Given this list of marker genes ZNF565, ENSG00000232884, CAD (carbamoyl-phosphate synthetase 2, aspartate transcarbamylase, and dihydroorotase), MBTPS1 (NCBI Gene Id 8720), DNHD1, SIN3B, SLC4A2, MAPKAPK3, CDK5RAP2, TIGD4, CDC5L, ANKFY1, BTN2A2, CARNMT1, C11orf68, MKLN1, GDF15, RNA5SP399, LINC00885, GTF2IP22, TMEM132D-AS1, ATPSCKMT, NR1D2, FNBP4, RPL30P11, OGDH (oxoglutarate dehydrogenase), MBTPS1-DT, KLKP1, ATL2, GSTCD, HOXC6, STAG3L2, DNM1, SPRY3, PDE4A, DERL3, LRRC8D, DNAJB4, SPMIP8, CARM1, RBL1, SNORD58B, LETM1, RNU6-353P, SLC15A1, C5orf34, NOL11, OSER1-DT, PCAT19, RPS15 (ribosomal protein S15), MGME1, PSMD5, CEP89, MSRB2, IFNAR1, ENSG00000271860, TGM2, EP400P1, MAN2C1, FGF13, FAM50A, B4GALT2, MDK, POLR2I, DDX11, EIF2AK3-DT, ERRFI1-DT, RNA5SP324, RPA3, TAB3, HSPG2, ATP5MFP2, NCOA4, CD46P1, MAP3K14-AS1, AKAP11 (NCBI Gene Id 79988), RPL12, RRP15, HMGN1P32, MYO6, DYNC2I2, LINC01257, NOP14, FGD2 (NCBI Gene Id 221472), AZGP1 (NCBI Gene Id 90053), ITGA2B, RPS18, INTS10, FKBP14, BRINP2, OR10V3P, CCND3, SHOC2, ENSG00000244791, TMCO1, DNTTIP1, BLTP3B, TSPAN1, CD59, IREB2, CCDC137, CBX3P4, ARMH4, PTEN, CHAF1A, PIK3AP1, KRT8, ERBIN-DT, MIR4441, PEAK1, FEM1C, FGFR1OP2, MEMO1, MXI1, XPO1, DCTN2, WRAP53, FAAHP1, FHL1P1, TMEM101, ZBTB22, ASB13, ZNF317, ITGA3, CREB3L1, EIF4A3, ANKS6, MXD1, ATG4B, FKBP8, LPAR5, THBS3-AS1, CYGB, SPATA3, TTC13, NADK2, RNVU1-25, MAP3K7, LINC01694 (long intergenic non-protein coding RNA 1694), ZFAND3, OBSL1, ZNF138, HIVEP2-DT, MDH2, ANO8, STK16, SCAMP5, HBE1, CHMP1A, DGKZ, MGAT1, RBM26-AS1, CCDC59, LRSAM1, LRP2, ERICH6-AS1, ZNF143-AS1, UBE2V1P4, ZNF236, RBPJ, RORA-AS1, UFSP1, BTF3P9, POLR1C, DCAF6, MT-CO1, TAOK1, RNF223, CCDC22, CNN2, RPS8, MTMR4, ARHGEF1, TPP1, INPP5D, TSPOAP1, LINC00963 (long intergenic non-protein coding RNA 963), MARCHF6, GAS8, CNGB1, UBTF, VPS54, EFHB, MIR4703, LINC00958, POLR3C, MIR616, ARFGEF2, FSD1, CDK2AP2, CLIC4, CDK1, SLC25A6, RNF115, CCDC192, PXMP4, XPC, RPS20, STAT6, MT-CO2, BCAR3, BCL3, SAXO1, PUS1, OR1AB1P (NCBI Gene Id 81090), CELF4, ZNF77, HDDC2, LINC01732, NUDT16 (nudix hydrolase 16), KCNAB2, NCAPG, GET4, SLC13A3, NSDHL, ARRDC3, CLEC16A (NCBI Gene Id 441746), CLCN2, PRR11, TSC22D1, PTPN4, RANBP1, C7orf50, ZNF202, PNPLA6, CRKL, OR13A1, WDR73, RSAD2, LINC03068, PPP4R3B-DT, E2F1, CYP2S1, PCNA, ARFIP1, ENSG00000187951, C8orf74 (chromosome 8 open reading frame 74), GPCPD1, TBC1D4, RASA4CP, BRF1, MIR1205, UPP1, SLC35E2A, HMGCS1, LINC01547, SCIRT, CHMP4C, RARG, PHLDB1, FSIP1, ZNF83, VWA5A, ZNF490, DLGAP4, USP49, SEMA5B, TCP11, ENSG00000260592, MIR548AW, HSP90AA1, IK, ICA1, CMTM3, GBE1, NLRP1, TRIM56, ALKBH3-AS1, PPM1K, MPND, MYO1A, AGBL3, MIR4659B, MDGA1, EOLA1-DT, IL6R, TMEM79, WDR64, TRGV6, DCAF11, USP27X, TMEM9, CFAP251, PAXBP1, SEC63, HMGN2P18, ASPHD1, ARF3, PA2G4, MYO18B, CDC20, TANK, SPN, TARDBP, LINC02842, DUSP10, PUDP, H4C3, LEF1, NDUFAF3, RIPOR3-AS1, ACSL3, DDB2, ATP6AP1L, GNAL, ODC1, SSR4P1, TMEM37, CCDC144CP, TLE6, CBY2, ZNF3, STK38, PLA2G6, RNU1-58P, UTP3, RIMBP3, TLK2, DENND2B, FHIP2B, DHRS13, HNRNPH3, ABLIM3, CELSR2, DCXR, USP27X-DT (USP27X divergent transcript), NUDT16-DT (NUDT16 divergent transcript), ZNF587, ADAMTS10, NMNAT1P5, ELOCP2, HSP90B1, TLCD1, CSNK1D, PPP6R1, ABCB9, ATP5MC1, FCER2, HOXC5, RPS2, ZNF609, MRE11, MIR3189, RPS11, KCNIP2-AS1, TMEM204, PPP2R5C, RCAN1, NME1, SHLD2, FABP5P3, BMAL1, FSCN2, PEX12, SUSD3, RPS6KA1, SYT7, CSTF3-DT, THAP1, SLC35E4, ENSG00000253986, GALNT4, CCDC91, TTI2, HDAC8, MIR6076, ZFYVE28, GPAT4, PIH1D2, SRP19, MAD1L1, CHCHD5, ERAP1, ZNF286A-TBC1D26, COX11, ATOX1, TBC1D10B, TMEM116, NFKBIE, SNRPB, ATF7-NPFF, RNU2-63P, MIR4530, EIF5, LTBP2, PLK1, SECISBP2L, ZP3, PRKAR1A, ADD3-AS1, HSPBAP1, WDR25, STK10, BTBD10 (BTB domain containing 10), PRSS8, CUX1, LINC01055, FLJ46284, HERC2P2, RNVU1-19, P4HB, CAMTA1-DT, HERC5, USP30, MBNL1, GLIS2-AS1, KAZALD1, RNU2-2P, INTS12 (integrator complex subunit 12), ZC3H12A, SRCAP (NCBI Gene Id 10847), GBA1 (NCBI Gene Id 82008), LINC02281, LEF1-AS1, NR2C2AP, RMC1, ZNF45, IGHA2, COG5, ALG2, DCXR-DT, MARCHF2, SLC3A2, TTYH1, ZNF574, ZNF212 (NCBI Gene Id 7988), NME2, MYH11, COPZ1, SH2B3, PLXND1, CIC, PLCD1, MIR548AX, DRAP1, PHC2, CLK3, INHA, EPS8L1, UIMC1, MICOS10-NBL1, ECI1, DCP1A, MYADM-AS1, WDR27, TRIP4, SYNCRIP, TCP11L2, HSPB1P2, CDT1, DNAJC16, PGA3, CRNDE (colorectal neoplasia differentially expressed), MT-TW, RAD1, ZNF274, RNVU1-6, LYPD5, DIXDC1, PHYH, TTC32, RAB30-DT, RBPJL, TYMS, ATP6V1H, SDR39U1, PLEKHG5, PPP4R3B, SNHG30, MFAP4, LINC00475, SPIRE2, PRKCSH, HMGN1, SF1, CDKL3, MELTF, SHISA5, RNA5SP428, ICE2, ELOVL1, HPCAL1, AHI1, DDX11-AS1, PIP4P1, TIGD1, DALRD3 (NCBI Gene Id 55152), NRSN2-AS1, CYTH4, EPCIP-AS1, ARRDC3-AS1, POLR2H, WDR62, BCAP29, EPM2AIP1, KPNB1-DT, ADO, SRGAP2, SLC12A2, ANKRD13C-DT, CELF3, OFD1, KLK10, SRGAP2C, SPCS2P3, UCKL1, UBE2D3-AS1, PRR5, TMEM248, SMPD4P1, BAHCC1, TCP10L2, CDC42SE1, COQ7-DT, LPXN, NUP155, DNPEP-AS1, CNPY1, TFAM (NCBI Gene Id 8033), BLTP3B-DT, WSB1, CCNI, PPM1K-DT, PHF5A, NPHS1, NEK2, MIR17HG, MTF2, COX7B, H3-3B (H3.3 histone B), ABHD2, LCNL1, UCP2, ABCC5, MAK16, HIVEP3, GOLGA1, ATF7IP (NCBI Gene Id 55729), NSL1, ANKRD49, MTMR8, ENAH, KDM4A, PSMD9, SMG1, ERRFI1, SLC25A28-DT, MIR3124, ZNF844, IMP3, LINC02863, TCF25, MAN2A2, CAMTA1, CSAG1, VMP1, CYBRD1, MIB2, SMG7-AS1, RNF145, CCND2, EXOSC10-AS1, SMG5, CAPN1-AS1, DVL1, TBC1D5, CAND1, SPRR2D, CHCHD2P1, MYLK, APLP1, CAMKMT, PIMREG, F12, RRAGA, HBD, RFC5, CCDC144A, LINC01518, ARV1, RPL27A, MIR5087, ETF1, PIP5K1C, SMG7, CREM, SOCS1, COL5A1, FAM83C, NLRC5 (NLR family CARD domain containing 5), CIAPIN1, CIMIP4, RPS7, NECAP1, LNCTSI, APLP2, NECTIN1, ZNF556, CHTF8, RPS6KC1, ITGB2-AS1, STXBP2, NELFCD (NCBI Gene Id 51497), QRICH1, PPAT, ARID3C, ZNF680, ZNF655, RCOR3, NAA35, ACSL1 (NCBI Gene Id 91249), NPTN, ZCCHC24, DHRS3, SNHG16, AGPAT3, DGLUCY, CCDC159 (coiled-coil domain containing 159, NCBI Gene Id 126075), ARAP3, ELF1, GTF2IP4, SEPTIN5, RNVU1-21, RPS5P2, BANF2, NOS3, CHD9NB, UTP4, INO80C, PLEKHA8, VDAC2P3, LINC00552, RAB5B, VAMP2 (vesicle associated membrane protein 2), MIR4522, SNORD1B, GPATCH3, ZBED5-AS1, FAM200B, RPTOR, FOXK2, HASPIN, RABGAP1L, IL17C, PDXK, PPM1B-DT, RPS21P8, ARID4A, CMPK2, GNG4, RPS17P5, PSMD4, RPL17, FMR1, FBXL5, N4BP1, MTND5P11 (NCBI Gene Id 100506169), LINC00933, CCN1, MPV17L2, C6orf120, ENSG00000255647, POP1, S100PBP, AQP1, AGRN, ERGIC2, C17orf58, SKA2, TBCB, INSR, SARAF, FAM170B-AS1, SCIN, SPTAN1, FOXS1, NMU, FUBP1, MARK4 (NCBI Gene Id 57787), LRRC37B, NUP62CL, MT-TD, TBCCD1, ZFP64, TCF4, SHOX2 (SHOX homeobox 2), GFI1B, CCZ1 (NCBI Gene Id 51622), MRC2, RNU5E-4P, MACC1, MT-TA, HMOX1, PAICS, MED1, FAM72A, KCNE3, GRB10, KLC3, NSUN3, MBD6, TJP3, TBL1X, RIDA, SCN1B, GPR179, IGSF9B (immunoglobulin superfamily member 9B), MET, INPP1, MIR4276, MIR3681HG, ATF7, RNU6-1069P, E2F3, MT-TN, ATP5F1C, SLC16A9, TMEM169, TAL1, NME1-NME2 (NME1-NME2 readthrough), ALKBH7, OR51B5 (olfactory receptor family 51 subfamily B member 5), DHX37, LINC02050, NSMF, RNVU1-28, MICOS10, ASH2L, ESR2, FHIT, DNAJB11, CASZ1, BZW1, DHX36, LINC01841, ENSG00000235480, HMGN2, NPEPL1, MICALL2, AGPAT1, LINC00899, ADNP, CIB1, GATAD2A, UPF3A, LIMS2, SLC43A2, ERCC6L2, HSPD1, HMGB2, LINC02288, DCAF16, CAPN7, ZNF441, ZNF263, RAB30, TM4SF19-AS1, SUZ12P1, LRFN4 (leucine rich repeat and fibronectin type III domain containing 4), BRWD1, ARHGAP22, NFYA, RN7SKP192, ASXL1, LINC01775, SUGP1, VTRNA1-1, COASY, ARHGAP11B-DT, MT-TQ, RNU7-124P, NRSN2, ZNF44, ANKRD17, BIVM (NCBI Gene Id 54841), CTCFL, ITGAE, NIF3L1, EXOC1, FAM72B, PURB, PLSCR3, CSRNP2, SLC39A3, DNAJB2, PIP4P2, GSTA4, ANP32E, DDX20, SUPT5H, MAD2L2, SLC49A3, ZNF346, ANXA2, CACNA1A, ACTN4, RXRB, PLK5, RNPC3, SLC29A1, CNTROB, STXBP4, TRPM4, ABCC3, ADAT1, SLC2A1, DDX60L, TTC41P, RUVBL2, EIF4A1P9, TEDC1, PTPA, NEPRO (NCBI Gene Id 285338), GABPB2, SEC61B, IQCN, RABAC1, ERCC6L2-AS1, ODC1-DT, KIAA2013, DNMT1, GPR17, MYADM, RGR, CXXC4-AS1, ENOX2, PHC1, NOL9, ZFP91-CNTF, GSS, DENR, LINC01145, GYPB, ZNF626, WNT3, TUBA1C, LINC01700, LRP3, KCNIP2, RIMBP3B, ERICH6, TRG-AS1 (NCBI Gene Id 100506776), TIPIN, CENPBD2P (NCBI Gene Id 65996), C1orf105, FGF1, CEACAM7, ACADSB, RPS27P30, RN7SL79P, TGOLN2, LMO2, AMD1P4, SEMA3B, TCEA2, TUFT1, SLC25A39, RBM17, CD226, CLIC2 (NCBI Gene Id 1193), PTP4A1, TUBGCP5, TDRKH, KIF2A, SCGB1A1, H1-2, PMS2, ZCWPW1, FAM200A, PHC2-AS1, FAR1, THADA, PKM, SYN3, VAC14, TRIM41, GTPBP3, TMC6, SYNPO, PTPN7, OXLD1, SLC39A11, ICMT, GRK1, TRAPPC2, MALAT1, SLX9, FAM157C, IKZF5, CCT8, NCOR2, CCDC9, RAB26 (RAB26, member RAS oncogene family), PSMA3-AS1, RNU6-1106P, LIMS1, FBXL8, GCK, BMS1P1, TTC3, IL4R, S1PR2, HOXC9, ATXN7L2, EMP3, TSSC2, CSTF3, PES1, AFF4-DT (AFF4 divergent transcript), PCED1B-AS1, RAP2C, HIF1A, RBBP5, ZNF286A, COTL1, RPSAP5 (NCBI Gene Id 319129), SLC15A3, NDUFV1-DT, XIST, KLC2-AS2, AP1G1, MORN5, UQCRB, DMTF1-AS1, RNPC3-DT, CR1L, RPL7A, ADGRE5, SNORD101, YIPF3, ENSG00000248607, FAM135A, GALNT7, LSM14A, EBAG9, FOXK1, UBE2D3, UBE2E1, SH3BP5L, CTSK, GAA, DYNC2LI1, CEP350, CCDC144BP, YARS1, MAU2, TSC22D4, MLH1, TMEM100, AKNA, LINC01169, MED28, DNAAF6, PCBD1, FAT1, HDAC5, COQ9, ZNF280B, ZSCAN25, DNAI7, STAT1, AXL, CD34, ARHGDIG, MIR4733, XPO6, LRRC46, ZNF101, H2BC15, SLC39A7, RPS9, SPPL2A, DNPEP, GP1BB, ANKRD36B, TMEM156, FBXO44, SNORA78, PSMC5, ICMT-DT, DYRK4, GSDMD, GIPC2, ACVR2A, PRDX6, CLCN3, EFHD1, CENPT, MT-CYB (NCBI Gene Id 4519), PCMTD1, LINC00620, MAGED2, UBE2Q2P1, MIR3154, NDUFB10P1, GEN1, THAP4, PRO1804, LRRC28, CNOT1, SPATA33, RHPN2, SF3B4, ATAD3B, CD68, ROM1, LINC00957, POC1B, LUC7L2, PHF23, BRSK1, GDF11 (NCBI Gene Id 10546), ENSG00000239008, FCHSD2, PRPSAP2, IGF2BP3, PTTG1IP, HSF1, BANP, LINC02327, RN7SL659P (NCBI Gene Id 106479462), ITPR1, MGRN1, PPCDC, KEAP1, TCP11L1, CHUK-DT, ZMIZ1-AS1, KIN, WDR20, RPL10A, PRDX1, BLOC1S2, SLC25A33, JOSD2, RUSC1, COL4A2, TMEM183A, PECR, DHFR2, CAMK2N2, GON4L, CTNNA2, GYPE, WBP1, RPL17-C18orf32, CDH15, RRS1-DT, CLPTM1L, MAGEA12, ZSCAN18 (NCBI Gene Id 65982), MIR7-3HG, ZNF136, SMARCD2, ACBD4, TRPV3, SF3A3, DLL4, LINC02371, EIF4E2, ACSM5, ZNF146, DBN1, CHD4, VPS33A, LMNA, STAP2, LSM10, GNG8 (G protein subunit gamma 8), CEBPA-DT, CAPN1, KPNB1, SRSF10 (NCBI Gene Id 89048), NRL, PCLAF, RN7SKP219, IMPA1, PAPLN, ACCS, SEC62, MRPL57, SAMD14, NFYC, STRIP1, NFIX, VWA7, USP54, ADGRB2, EGLN3, PHF19, PLEKHG2, ZFAND3-DT, GART, FCHSD1, SDSL, CDK12, LINC02129, FBXO17, INTS9, HSPE1-MOB4, TDRKH-AS1, DAXX, ZNF131, SNX12, HIBCH, DMAP1, MED22, RNA5SP505, EIF4G1, YJU2, ZNF292, ACHE, WNT10A, UCA1-AS1, ZNF582, SPTSSA, FAAP20, LTV1, SCARB1, CCNC, EIF3H, CSAG4, EXOC6, SLC12A2-DT, HTR5A, APBA2 (amyloid beta precursor protein binding family A member 2), RNFT2, LMTK3, RN7SL444P, LINC03008 (NCBI Gene Id 100128325), OPN4, KMT2C, ZZZ3, GNAS, PKIB, RBM39, KCNH2, SNORD38A, TBL1XR1, MT-TC, LINC02783, AP3M2, LRAT, RAPGEF1, SLC27A1, MECOM, PSIP1, EIF2AK3, TOP3B, RBM26, CCAR2, FURIN, SEPTIN7, GJC2, ACAP3 (ArfGAP with coiled-coil, ankyrin repeat and PH domains 3), DOLPP1, RPS12, PARP12, ETFA, CRAT, RNU1-1, CIMIP5, PURG, CYP4Z1, RN7SL346P, ZNF736, GTF3C1, TMEM18, CYB5D1, RPL30P5, BAGE2, MPC2, LINC00431, LINC01399, MYO9B, SMNDC1, ENSG00000259182, VDAC3, SLC35E1, CMIP, TMEM209, GLB1L, ADA, RNU6-240P, VARS2, KLHDC9 (NCBI Gene Id 126823), NKAPD1 (NCBI Gene Id 55216, NKAP domain containing 1), VILL, ACBD5, SNHG32, OSER1, TICRR, PNCK, CLASRP, GCHFR (NCBI Gene Id 2644), RNU6ATAC, ACO2, GCDH, PCSK7, ENSG00000233017, SPOPL-DT, ZNF100, PCED1A, SNX5, VPS33B-DT, AURKAIP1, SPRED1, DDR1, CCDC12, MAPK14, PJVK (pejvakin), CATSPERG, SLC26A8, FAM174C, SF1-DT, GMFB, MOV10L1, CPEB4, PGP, CAPN3, CDC20-DT, H4C5, UBALD2, CORO6, NLRP7, FAM83F, NCSTN, SIPA1L1, NME4, SLC38A8, SLC41A3, TFAP4, GRK6 (NCBI Gene Id 2870), PRKAB1, KDM2A, ZNF48, NDUFV1, SMARCD3 (NCBI Gene Id 6604), PPIL3, USP22, LINC02525, TMEM117, ZNF428, GABBR2, GAS5, METTL25, BAIAP3, TCN2, DBR1, ATP1B2, TSC1, GORASP2, RPS2P4 (ribosomal protein S2 pseudogene 4), GCC2, EMD, UBE2I, PSD2-AS1, PSMB6, DYNLT2B, TMCO1-AS1, INAFM1, RNU6-268P, ANK3, LIN28B, INKA2, INTS9-AS1, FTSJ3, DGUOK, TSPAN32, SLC29A4, ZNF442, CAND2, SLC22A18, CDS2, NECAB2, EML3, RPS19, MSX1, TTC32-DT, SNHG9, BAIAP2, AKR1E2, ZNF433-AS1, ZNF254, NDUFA2, B3GALT1-AS1, ICA1-AS1, ZFP36L1, HISLA, ARL13B, SLC16A6, PUF60, RC3H2, ARHGEF2, ACOT7, NDUFA8, LINC01132 (long intergenic non-protein coding RNA 1132), GDPGP1, TMCO4, WBP4, ZNF143 (NCBI Gene Id 7702), FAR1-IT1, RPS6, CETN2, NECTIN2, POC1B-AS1, TDH, MAEA, ARID1A, ZBTB37, MATR3, FDXR, LINC02882, SKA3, RNF139-DT, EPS15L1, RRS1, SELENOW, JPX, RAC1 (NCBI Gene Id 5879), XPO4, ZNF513, SRRT, VRK2, LINC01719, SUSD6, RAB40B, HERC2, GDPD3, HSPE1P3, C1orf54, KMT2A, SLC43A3, NAA38, MIR3667HG, C6orf89, SYNGR2P1, MIR7-3, SHPRH, ZNF76, HBG2, DRAIC, RNU4-13P, OGA, TRAPPC1, MTCO3P12, ALDH9A1, PPP1R9B, SUMO2P17, TIMM17A, MICOS10-DT, GSK3B-DT, HSP90AB1, RAPGEFL1, ENSG00000273727, SARS2, MIR6802, MMS22L, RNF167, OARD1, ANKRD13C, MAP2K2, FKBP4, HMG20A, TYK2, TMA7B, CLSTN1, LINC01029, ELAVL1, FAAP24, SPC24, TYRO3, HMGN4, TNFSF14, TSPYL6, CCNT1, DAZAP1, AHCTF1, SOX6, MED28-DT, MYL11, ZNF663P, TBC1D3P5, DPP9, PUS1-AS1, IRF9, LTBP4, DCAF4, ECE1, CHID1, INTS13, SLC15A4, C10orf88, CMTM4, HMGN2P34, UACA, ZBED5, MAGOH, USP1, RENBP, BABAM1, DNAJC6, C1orf159, PDZK1IP1, ETS2 (NCBI Gene Id 2114), GRK4, SNORD48, ENSG00000259881, EOLA1, CSDE1, ZKSCAN2, GALM, SMG6, TENT2, ASH1L, BAZ2A, NRBF2, ADARB1, HNRNPH1, AMER1, HSPBP1, TFRC, RNU6-1136P, SLC25A4, TRAJ7, GCNA, NUP35P1, TMEM198B, SLC25A28 (NCBI Gene Id 81894), HSPE1, TFCP2, SEPTIN7-DT, RUSC1-AS1, KCNH4 (NCBI Gene Id 23415), ZFP91, BRIX1, ABCC11, MIS18A, RNU4-2, CRTC3, LINC02022, P3H3, SIL1, RNU2-17P, ZNF286B, SH2D3C, RPL37P13, DRG2, CORO1C, CXXC1, RGS9, STYXL1, SREBF2, DMTF1, GSK3B, TAS1R1, NCL, RNF214, FAM234A, HUWE1, SCNN1B, DRAXIN, ANKRD13D, SCRIB, SUB1, NF1, NSD2, ARHGEF17, WFDC3, MIR191, CLASP2, MT-TY, RBM47, BRD7, TTC23, UBE2Z, SLC25A11, ZMIZ1, PCBP1-AS1, MEF2A, ZNF582-DT, UTP25, ASPSCR1, CLPTM1 (NCBI Gene Id 1209), PI4KB, CCNG2, LINC02794, NIPSNAP2, TATDN3, PREPL (NCBI Gene Id 9581, prolyl endopeptidase like), MIR99AHG, RUNX1T1, NKIRAS2, EML2, PACS2, ADGRF2P, UBXN7-AS1, CCT5, CMAHP, PCMTD1-DT, KMT2E, PRKRA, COL6A4P1, SYT5 (NCBI Gene Id 6861), POU3F2, RNVU1-26, RGS16, TRAPPC9, WDR74, GEMIN8, UHRF2, here is a description of the gene set: Genes containing one or more binding sites for (ZNF184) in their promoter regions (TSS -1000,+100 bp) as identified by GTRD version 20.06 ChIP-seq harmonization. species: Homo sapiens Human Gene Set: ZNF184_TARGET_GENES from publication Yevshin I, Sharipov R, Kolmykov S, Kondrakhin Y, Kolpakov F (PMID 30445619)